The following is a description of a gene set: Human Gene Set: GOBP_CEREBRAL_CORTEX_DEVELOPMENT The progression of the cerebral cortex over time from its initial formation until its mature state. The cerebral cortex is the outer layered region of the telencephalon. species: Homo sapiens, and this is the list of marker genes: TFAP2C, ROBO1, PAX6, NDE1, ATOH1, NDEL1, CEP120, EMX2, CNTNAP2, ASPM, CRK, DISC1, TRAPPC9, GART, GSK3B, CCDC85C, SUN2 (Sad1 and UNC84 domain containing 2), SLIT2, BBS4, EGFR, ARHGAP11B, XAB2, PEX13, GLI3 (GLI family zinc finger 3), PALS1, SLC2A1, BNIP3, POU3F2, RHOA, NOTCH2NLA, BAX, LRP8, CSNK2A2, SRD5A1, BTBD3, RELN, SRGAP2C, P2RY12, CTNNB1, NTRK2, PEX5, NEFL, SLC38A2, TACC2, PLCB1, TBR1, CCDC39, SRGAP2, NPY, PSEN1, MBOAT7 (membrane bound O-acyltransferase domain containing 7), FOS, CCDC141, KIF26A (NCBI Gene Id 26153), NARS1, SUN1, SMO, GRIA1, CDH2, NOTCH2NLB, NR2E1, TSC1, COL3A1, LAMB1 (laminin subunit beta 1), KDM1A, YWHAE, DMRTA2, AKIRIN2, FUT10, MDK, PTPRS, DIXDC1, CDK5R2, CDK5, FILIP1, CDK5R1, EMX1, BMERB1, WDR47, FKTN, DAB1, EFHC1 (NCBI Gene Id 94915), SOCS7, MCPH1, LHX2, TRA2B, FOXG1, NSUN5, HIF1A, BBS1, FLNA, WDR62, PAFAH1B1, ATIC, MDGA1, EOMES, BBS2, CDON, FOXP2, PHACTR1, PPP1R9B, TMEM14B, NF1, FBXO45, TACC3, FAT4, TUBB2A, KIF14, LHX6, ZMIZ1, POU3F3, FGF13, KCNA2, MGARP (NCBI Gene Id 84709), NOTCH2NLC, TUBA1A, CRKL (NCBI Gene Id 1399), HTR6, ADGRG1, ARX, ASCL1, RTN4, NCOA1 (NCBI Gene Id 8648), RAC1, DAB2IP, PAX5, NKX2-1, TUBB2B, TACC1, MKKS, SYNE2